Given this list of marker genes SLC2A1, ABCB1, XRCC6, OXSR1, MICU1, YBX3, ARHGEF2, STK39, SLC25A23, ERRFI1, NINJ1, RCSD1 (NCBI Gene Id 92241), AKR1B1, EPO, NFAT5, AQP1, LETM1 (leucine zipper and EF-hand containing transmembrane protein 1), WNK1, FXYD2, EFHD1, WNK3, FBP1, here is a description of the gene set: species: Homo sapiens Any process that results in a change in state or activity of a cell (in terms of movement, secretion, enzyme production, gene expression, etc.) as a result of detection of, or exposure to, a hyperosmotic environment, i.e. an environment with a higher concentration of solutes than the organism or cell. Human Gene Set: GOBP_CELLULAR_HYPEROSMOTIC_RESPONSE